The following is a description of a gene set: Reactome Pathway: Regulation of Glucokinase by Glucokinase Regulatory Protein part of: Glycolysis Glucokinase (GCK1) is negatively regulated by glucokinase regulatory protein (GKRP), which reversibly binds the enzyme to form an inactive complex. Binding is stimulated by fructose 6-phosphate and sorbitol 6-phosphate (hence high concentrations of these molecules tend to reduce GCK1 activity) and inhibited by fructose 1-phosphate (hence a high concentration of this molecule tends to increase GCK1 activity). Once formed, the complex is translocated to the nucleus. In the presence of high glucose concentrations, the nuclear GCK1:GKRP complex dissociates, freeing GCK1 to return to the cytosol. The free GKRP is thought also to return to the cytosol under these conditions, but this return has not been confirmed experimentally. Possible physiological roles for this sequestration process are to decrease futile cycling between glucose and glucose 6 phosphate in hepatocytes under low-glucose conditions, and to decrease the lag between a rise in intracellular glucose levels and the onset of glucose phosphorylation in both hepatocytes and pancreatic beta cells. species: Homo sapiens, and this is the list of marker genes: SEC13, NUP205, GCK (NCBI Gene Id 2645), NUP85, NUP160, NUP50, TPR, NUP210, NUP42, NUP214, NUP88, RAE1, NUP93, NUP98, POM121C, NUP37, NUP133, NUP43, NDC1, NUP58, RANBP2, NUP155, NUP188, POM121, AAAS, NUP62, SEH1L, NUP107, NUP54, GCKR, NUP35, NUP153